Given this list of marker genes PSMA6, ZNF287, STK25, THBS2, SCN8A, NECTIN4, ZNF324B, TMEM220, REM2 (RRAD and GEM like GTPase 2), SLC4A9, SLC39A1, TOR1AIP1, TTC4 (NCBI Gene Id 7268), RNF141, RANGRF, TREX1, PSEN1, SPATC1, RAMP1, VPS28, USP11, SEMA7A, SOX2-OT, ZNF678, SNAP91, SMAP2, CCN6, SEC61B, TUSC2, TK1, PRKRA, RSPH3, U2AF1, TRIM54 (tripartite motif containing 54), UBFD1, UTP11, SLC4A2 (NCBI Gene Id 96677), SEMA6A, ZNF131, SART3, SEC11A, WDR33, TTC7A, SHISA6, EIPR1, TDRD7, RIT1, PRMT3, TRIM16, ZCCHC9, RTN4, SDC3, SPATS2L, ZNF775, TOP3A, RANBP9, ZFC3H1, SERHL2, ZNF861P, TP53I13, ZNF394, TBCCD1, TCP10L3, ZMYND11, UBE2D1, TRIML1, GFUS, SEPTIN3, TNFAIP3, SEC23B, SGO2, RHOH, SLC25A3, SDCCAG8, SAGE1, ZFAND5, STARD4, RNF113A, UTS2B, UBE4B, RHBDL2, ZBED6, PRKAG3, PSMA2, SOX11, ZNF530, SEPHS2, SLC9A6, SHMT2, ZC3H13, ROCK1, TFF2, SRRM3, ZNF28, RGS4, SULT1C2, STK32A, RSPH1, PUM2, TPMT, TRAPPC6B, SETD1B, TSC22D2, SPATA22, TPSAB1, YIF1B, TLR4, SMAD1, TAS2R9, RAB8B, USP34, UBL7, XIST, SAMSN1, TULP2, TBC1D4, RNF10, DENND2B, TRIM55, PTH2R, RRM1 (NCBI Gene Id 6240), PSMG2, SLC16A4, TINF2, YY1, RNF167, TOP2B, TIFAB, RLF, SLC41A1, PSPN, SUCLG2, RASA1, ZNF277, SNX3, LMNTD2-AS1, PROCR, ZNRF2, TTL, TTC33, TPR, TPI1, USP43, RNF19A, PYHIN1, TRABD, TMEM139, TUBB4B, RSPH10B2, RAB2B, RNF150, SLC45A1 (NCBI Gene Id 50651), PROM1, RPN1, UBA6 (NCBI Gene Id 55236), SLC35F3, RTP1, RAB35, SYN2, ZAN, ZNF655, STX10, TTC12, ROS1, SH2D1A, ZCCHC13, SF3B4, UBA3, UTP23, RCOR1, UBL3, EMC4, SLC9A8, TMBIM1, SRL, SUMO4, RPS6KB1, STARD3, TYSND1, SPDYA, TSNAX, TMEM208, ZSCAN9, ZNF557, RPL26L1, YPEL5, SAP30BP, TRIP12, DNAAF10, S100P, PTK2B, ZDHHC8BP, SLC25A46, UBE2U, WNT9B, SPACA7, ZNF346, here is a description of the gene set: Genes down-regulated in comparison of non-suppressive T cells versus activated regulatory T cell (Treg). Human Gene Set: GSE15659_NONSUPPRESSIVE_TCELL_VS_ACTIVATED_TREG_DN from publication Miyara M, Yoshioka Y, Kitoh A, Shima T, Wing K, Niwa A, Parizot C, Taflin C, Heike T, Valeyre D, Mathian A, Nakahata T, Yamaguchi T, Nomura T, Ono M, Amoura Z, Gorochov G, Sakaguchi S (PMID 19464196) species: Homo sapiens Gene expression profiles of subsets of CD4+ T cells according to their expression of FoxP3 and CD45RA were compared. FoxP3 is a key transcription factor for the development and function of natural CD4+ regulatory T cells (Tregs). Here we show that human FoxP3+CD4+ T cells are composed of three phenotypically and functionally distinct subpopulations: CD45RA+FoxP3low resting Tregs (rTregs) and CD45RA-FoxP3high activated Tregs (aTregs), both of which are suppressive in vitro, and cytokine-secreting CD45RA-FoxP3low non-suppressive T cells. The proportion of the three subpopulations characteristically altered in cord blood, aged individuals, and patients with immunological diseases. Terminally differentiated aTregs rapidly die while rTregs proliferate and convert into aTregs in vitro and in vivo as shown by the transfer of rTregs into NOD-scid-common gamma-chain-knockout mice and by TCR sequence-based T cell clonotype tracing in peripheral blood of normal individuals. Taken together, the dissection of FoxP3+ cells into subsets enables one to analyze Treg differentiation dynamics and interactions in normal and disease states, and to control immune responses through manipulating particular FoxP3+ subpopulations.